Given this list of marker genes Fam169b, Rmnd5a, Pdk1, Slc16a5, Ilvbl, Rgl2 (NCBI Gene Id 19732), Ctse, Itpr2, Cryl1 (NCBI Gene Id 97930), Rps6kl1, Tmem121, Aqp11, Cdca7, Strbp, Frat2, Rrp12, Trbv1, Fam78a, Trib2, Cd2, Lox, Actn1, Fbp1, Snai3, Pdlim4, Xrcc6, Tbxa2r, Dgka, Brd3, Naxd, Olfml3, Cenpv, Endou, Notch3, Ramp1, Tmem108, Slc5a9, Rapgef3, Prkcd, Il17rb, Ppp1r1c, Tacc1, Gldc, Acvr2b, H19, Nt5dc2, Igf1r, Arhgap15, Ly6d, Ephx1, Nck2, Tapt1, Gm525, Rnpepl1, Pdxp, Gpr83, Ttc3, Lman2l, Ccl9, Alkbh1, Inafm2, Mib2, Igip, Tspan32, Acss1, Hibadh (3-hydroxyisobutyrate dehydrogenase), Cd81, Prelp, Trim28, Slc29a1, Dap3, Fyb1, St6gal1, Bgn (NCBI Gene Id 12111), Pou6f1, Aldh2, Msh6, Marcks, Trbv8, Nipbl, Dntt (NCBI Gene Id 21673), Ppargc1b, Cd6, Nav1, Mapk1, Art4, Txnip, Pitpnm2, Rhno1, Tcf7, Ebf3, Ets1, Satb1, Cox6a2, Pard6g, Celf2, Pld4, Nisch, Sla, Trbv31, Anp32e, Dpp4, Rgcc, Mmp2, Snx30, Sox4, Adgre5 (adhesion G protein-coupled receptor E5), Kmt2a, Sh2d1a, Plekhg2, Slf2, Stk4, Cd27, Setd1b, Tpst1, Prkcb, Col5a1, Zer1, Tdrp, Trbv11, N4bp2l1, H3f3b, Tpcn1, Cd3d (NCBI Gene Id 12500), Hdac7, Acta2, Llgl1, Col6a1, Dtx1 (deltex 1, E3 ubiquitin ligase), Bcl7a, Klhl24, C3, Cxcl12, Zfp260, Ctla4, Chchd3, Ets2, Gfi1, Mtf2, Abhd8, Bcl11b (NCBI Gene Id 78682), here is a description of the gene set: T cells develop in the thymus and are critical for adaptive immunity. Natural killer (NK) lymphocytes constitute an essential component of the innate immune system in tumor surveillance, reproduction, and defense against microbes and viruses. Here, we show that the transcription factor Bcl11b was expressed in all T cell compartments and was indispensable for T lineage development. When Bcl11b was deleted, T cells from all developmental stages acquired NK cell properties and concomitantly lost or decreased T cell-associated gene expression. These induced T-to-natural killer (ITNK) cells, which were morphologically and genetically similar to conventional NK cells, killed tumor cells in vitro, and effectively prevented tumor metastasis in vivo. Therefore, ITNKs may represent a new cell source for cell-based therapies. Genes down-regulated in ITNK cells (T-lymphocyte progenitors (DN3 cells) reprogrammed to natural killer (NK) cells by ablation of BCL11B gene), compared to the parental DN3 cells. species: Mus musculus from publication Li P, Burke S, Wang J, Chen X, Ortiz M, Lee SC, Lu D, Campos L, Goulding D, Ng BL, Dougan G, Huntly B, Gottgens B, Jenkins NA, Copeland NG, Colucci F, Liu P (PMID 20538915) Mouse Gene Set: LI_INDUCED_T_TO_NATURAL_KILLER_DN